Given this list of marker genes SNRNP70, SNRPC, ISG20, SNRPB2, PRPF8, GEMIN5, COIL, SNRPA, here is a description of the gene set: Binding to a U1 small nuclear RNA (U1 snRNA). Human Gene Set: GOMF_U1_SNRNA_BINDING species: Homo sapiens